The following is a description of a gene set: Reactome Pathway: AMPK-induced ERAD and lysosome mediated degradation of PD-L1(CD274) part of: Regulation of PD-L1(CD274) Post-translational modification species: Homo sapiens Adenosine monophosphate (AMP)-activated protein kinase (AMPK) is the main sensor of energy stress, playing a part in adaptive responses to falling energy levels. AMPK is a heterotrimeric protein complex, comprised of a catalytic α subunit (PRKAA1,PRKAA2), a β subunit (PRKAB1, PRKAB2), and a γ subunits (PRKAG1, PRKAG2, PRKAG3). During energy deprivation, cellular levels of AMP are increased while ATP levels decline, leading to AMPK activation because of allosteric changes.. Activated AMPK phosphorylates PD-L1 (CD274) at S195 which leads to abnormal glycosylation due to improper mannose trimming, thus leading to endoplasmic reticulum (ER) accumulation of PD-L1 and activation of ER-associated protein degradation (ERAD) pathway for the degradation of abnormally glycosylated PD-L1. AMPK promotes not only ERAD-mediated but also lysosome-mediated degradation of PD-L1. Mechanistically, activated AMPK phosphorylates a specific serine residue (Ser283) on PD-L1, which disrupts its interaction with CMTM4 and consequently facilitates PD-L1 degradation via the lysosomal pathway., and this is the list of marker genes: PSMB2, OS9, PSMA1, PSMA5, RNF185, ERLIN2, ERLEC1 (NCBI Gene Id 27248), RNF5, ADRM1, PSMB7, PSMC4, PRKAA2, PSMB3, PSMA4, PSMA7, DERL2, VCP, PSMB6, PSMA3, PSMC5, PSMD13, PSMA2, PSMD3, PRKAG3, UBC, CD274, PSMC6, UBB, PSMB5, PSMD1, PSMA6, SEM1, PSMC2, DERL1, PRKAB1, PRKAB2, DERL3, PSMD8, PSMB4, SEL1L (SEL1L adaptor subunit of SYVN1 ubiquitin ligase), PRKAG2, UBA52, PSMC1, PSMC3, ERLIN1, PSMB1, PSMD12, PSMD14, PSMD11, PSMD7, RPS27A, PSMD6, PRKAG1, PSMD2, PRKAA1